The following is a description of a gene set: Mouse Gene Set: CUI_B_CELL_IL17D_RESPONSE_DN Cytokines mediate cell-cell communication in the immune system and represent important therapeutic targets. A myriad of studies have highlighted their central role in immune function, yet we lack a global view of the cellular responses of each immune cell type to each cytokine. To address this gap, the authors created the Immune Dictionary, a compendium of single-cell transcriptomic profiles of more than 17 immune cell types in response to each of 86 cytokines (>1,400 cytokine-cell type combinations) in mouse lymph nodes in vivo. A cytokine-centric view of the dictionary revealed that most cytokines induce highly cell-type-specific responses. For example, the inflammatory cytokine interleukin-1β induces distinct gene programmes in almost every cell type. A cell-type-centric view of the dictionary identified more than 66 cytokine-driven cellular polarization states across immune cell types, including previously uncharacterized states such as an interleukin-18-induced polyfunctional natural killer cell state. from publication Cui A, Huang T, Li S, Ma A, Pérez JL, Sander C, Keskin DB, Wu CJ, Fraenkel E, Hacohen N (PMID 38057668) species: Mus musculus Genes negatively differentially expressed in cell type: B cell upon treatment with cytokine: IL-17D in mouse lymph nodes in vivo., and this is the list of marker genes: Cxcr4, Fos, Klf2, Jund, H2-T23 (NCBI Gene Id 15040)